Given this list of marker genes GDE1, RGS2 (regulator of G protein signaling 2), MAPK14, FAM89B, NDUFA2, MLEC, IMPDH2, COL4A1, DAG1, SMARCD2, MINDY2, NXF1, ETV5, DGCR2, RPL12, TKT, TULP3, CDIPT, NFIL3, CALM2, MMP12, CEP57, H1-10, OSER1, RABIF, DGAT1, MAP3K14, CYTIP, NASP, H2BC10, DPYD, PAPSS2, GSTA2, GADD45A, OXA1L (OXA1L mitochondrial inner membrane protein), CKAP5, SYT1, KPNA5, PLCB1, RALY, JUNB, TRAM2, TOB1, H2BC4 (H2B clustered histone 4), OCEL1, LTA4H, GALNT1, AGO2, AHCY, UBE2G1, EVI2A, PODXL, ATG9A, TCAF1, CCDC6, EEF2, ACAT2 (acetyl-CoA acetyltransferase 2), SLC25A6, CNPPD1, H3C4, PDE6D, SPTAN1, UCP2, SWAP70, PITPNM1, H2BC12, CDK14, NPTXR, ANKRD46, FOS, CALCOCO1, H2BC14, PPP1R13B, MAPK7, CAT, CALM1, PRPS2, H2BC7, SLC16A1, EIF4EBP2, CD86, ESS2, CTDSP2, H2BC13, SLCO3A1, SOCS6, GLS, BCL2L11, IDH2, NRIP1, N4BP2L1, KIF13B, RHOG, PLEKHO2, IDH1, RPS8, FEM1C (NCBI Gene Id 84463), TUBB3, ATP1A1, CYRIA, H2BC5, KDM4A, ZCCHC24, RETREG3, CACNA2D2, CDK8, KYAT3, CPNE1, CADPS, FAM114A1, POLR2A, CASP9, ACADSB, PCNA, ULK1, PPM1D, HEXIM1, VPS8, MPST, NHERF1, RNF103, GAB1, HECTD4, ING1, TP53I3 (tumor protein p53 inducible protein 3), RPLP1, PLOD1, HDAC5, H2BC6, CEBPD (NCBI Gene Id 1052), ABHD5, TAF5, H2BC11, PABPC1, PRCP, CDC42EP4, PCBP2, STX6, FGL2, BICD2, FNBP1, ST8SIA4, CSHL1, ZNF423, ZNF10, DOP1B, HLA-E, SLC35A1 (NCBI Gene Id 10559), AP3S2, FGF1, GPD1L (NCBI Gene Id 23171), PTEN, PLAGL1, SV2B, TCFL5, POLG2, TUBB4A (NCBI Gene Id 1864), LRPAP1, JMJD1C, ERCC6, MEOX2, POLB, SERPINB1, PTPRA, ENC1, H2AC6, JUND, MEGF9, H2AX, NCAPD2, H2BC15, EVI2B, KRTAP26-1, IL1RAP, EFNB2 (NCBI Gene Id 1948), WIPI2, CCS, ITPR2, ECI1, ALOX5, TSC22D3, DUSP5, CDKN1C, GALNT10, GLCE, WDR47, RPS2, ACAA1, CRYBG3, IP6K1, DIAPH2, ASMTL, MARCKSL1, HADHA, NAP1L1, AHCTF1, GNAI2, H2BC21, RPS14, TUBB4B, here is a description of the gene set: from publication Shinohara H, Behar M, Inoue K, Hiroshima M, Yasuda T, Nagashima T, Kimura S, Sanjo H, Maeda S, Yumoto N, Ki S, Akira S, Sako Y, Hoffmann A, Kurosaki T, Okada-Hatakeyama M (PMID 24833394) The activation signaling of transcription factor nuclear factor-kB (NF-kB) plays central role for immune system. One of key kinase mediating this pathway is TAK1 in adaptive and innate immunity. However, role of TAK1 in B cell receptor signaling is still unclear. To know effects of TAK1-deletion on the gene expression induced by anti-IgM, we performed the time course analysis in comparison of wild type with TAK1-deleted splenic B cells. Genes down-regulated in B lymphocytes treated by anti IgM for 24h: wildtype versus MAP3K7 knockout. Human Gene Set: GSE41176_WT_VS_TAK1_KO_ANTI_IGM_STIM_BCELL_24H_DN species: Homo sapiens